Given this list of marker genes ANXA3, FST, AK1, S100A6, IGFBP4, ELN, CAV1, GPX3, COL4A5, CCN3, FGF7, TINAGL1 (NCBI Gene Id 64129), MDM2, IGFBP6, CD81, TIMP2, CCNG1, EEF2, COL8A1, TIMP3, CCND2, DCN, CTTN, SERPINE2, CCND1, APP, CDKN1A, PRRX2, MGP, MFAP5, here is a description of the gene set: Genes up-regulated in MEF cells (embryonic fibroblasts) from PARP1 knockout mice. species: Mus musculus from publication Simbulan-Rosenthal CM, Ly DH, Rosenthal DS, Konopka G, Luo R, Wang ZQ, Schultz PG, Smulson ME (PMID 11016956) Human Gene Set: SIMBULAN_PARP1_TARGETS_UP Poly(ADP-ribose) polymerase (PARP) is implicated in the maintenance of genomic integrity, given that inhibition or depletion of this enzyme increases genomic instability in cells exposed to genotoxic agents. We previously showed that immortalized fibroblasts derived from PARP(-/-) mice exhibit an unstable tetraploid population, and partial chromosomal gains and losses in PARP(-/-) mice and immortalized fibroblasts are accompanied by changes in the expression of p53, Rb, and c-Jun, as well as other proteins. A tetraploid population has also now been detected in primary fibroblasts derived from PARP(-/-) mice. Oligonucleotide microarray analysis was applied to characterize more comprehensively the differences in gene expression between asynchronously dividing primary fibroblasts derived from PARP(-/-) mice and their wild-type littermates. Of the genes monitored, 91 differentially expressed genes were identified. The loss of PARP results in down-regulation of the expression of several genes involved in regulation of cell cycle progression or mitosis, DNA replication, or chromosomal processing or assembly. PARP deficiency also up-regulates genes that encode extracellular matrix or cytoskeletal proteins that are implicated in cancer initiation or progression or in normal or premature aging. These results provide insight into the mechanism by which PARP deficiency impairs mitotic function, thereby resulting in the genomic alterations and chromosomal abnormalities as well as in altered expression of genes that may contribute to genomic instability, cancer, and aging.